Given this list of marker genes BZW2, MRPS11, EIF3B, CPSF2, BCCIP, DNAAF3, PRKCI, ANKRD13A, MYL12A, SMC3, ARPC4-TTLL3, UQCRC2, OGA, WASF2, FAM53C, PMVK, ANKMY2 (NCBI Gene Id 96008), BCL6, COMMD6, TADA3, SYVN1, TAF15, MRPL46, ENSG00000239137, SNX8, STK35, HYAL2, UROS, HEXIM1, EED, POLR1G, NDUFB1, WRAP53, KCNIP2-AS1, PAFAH1B3, PPP1R13L, ARPC4, NOCT, SIRT4, here is a description of the gene set: from publication Yevshin I, Sharipov R, Kolmykov S, Kondrakhin Y, Kolpakov F (PMID 30445619) Human Gene Set: FOXQ1_TARGET_GENES Genes containing one or more binding sites for (FOXQ1) in their promoter regions (TSS -1000,+100 bp) as identified by GTRD version 20.06 ChIP-seq harmonization. studied in species Homo sapiens